The following is a description of a gene set: The term splanchnic vein thrombosis encompasses Budd-Chiari syndrome (hepatic vein thrombosis), extrahepatic portal vein obstruction (EHPVO), and mesenteric vein thrombosis; the word splanchnic is used to refer to the visceral organs (of the abdominal cavity). studied in species Homo sapiens Human Gene Set: HP_SPLANCHNIC_VEIN_THROMBOSIS Splanchnic vein thrombosis, and this is the list of marker genes: SH2B3, CALR, PIGM, PIEZO1, PRSS1, MET, PRSS2, CPA1, TP53, CD55, KCNN4, NOTCH1, CASR, PIGA, F5, TET2, CTRC, TRPV6, CTNNB1, JAK2, SERPINC1, EPAS1, SLC4A1, CFTR, MPL, SPINK1